Given this list of marker genes Mbnl1, Dhx9, Ireb2, Ptbp1, Hnrnpa2b1, here is a description of the gene set: studied in species Mus musculus Mouse Gene Set: GOMF_REGULATORY_REGION_RNA_BINDING Binding to a RNA region that regulates a nucleic acid-based process. Such processes include transcription, DNA replication, and DNA repair.